Given this list of marker genes Med20, Med9, Cbx7, Med4, Scaf8, Pwwp2b, Med15, Zmynd8, Med27 (mediator complex subunit 27), Med23, Brd4, Ldb1, Ccnk, Ccnt1, Ncbp1, Med17, Cdc73, Med22, Ikzf1, Pwwp2a, Med18, Med16, Med24, Med6, Leo1, Med7, Parp1, Med30, Med26, Supt4a, Map2k1, Cdk13, Gtf2f1, Med25, Ccnt2, Supt4b, Ercc6, Med31, Med21, Cdk9, Ell3, Eapp, Med1, Ell, Med28, Ncbp2, Supt6 (NCBI Gene Id 75730), Dab2, Med19, Btbd18, Med10, Med8, Tex24, Kat7, Ctnnb1, Med14, Supt5, Med29, Ell2, Med11, Cdk12, here is a description of the gene set: Mouse Gene Set: GOBP_POSITIVE_REGULATION_OF_DNA_TEMPLATED_TRANSCRIPTION_ELONGATION Any process that activates or increases the frequency, rate or extent of transcription elongation, the extension of an RNA molecule after transcription initiation and promoter clearance by the addition of ribonucleotides catalyzed by a DNA-dependent RNA polymerase. studied in species Mus musculus